Given this list of marker genes PTPN2, CD300LF, PARP14, PTPRC, CD40, STAT6, JAK1, IL2RG, STAT5A, JAK3, IL4, IL4R, here is a description of the gene set: The series of molecular signals initiated by interleukin-4 binding to its receptor on the surface of a target cell, and ending with the regulation of a downstream cellular process, e.g. transcription. species: Homo sapiens Human Gene Set: GOBP_INTERLEUKIN_4_MEDIATED_SIGNALING_PATHWAY